The following is a description of a gene set: studied in species Homo sapiens Human Gene Set: GAVISH_3CA_METAPROGRAM_EPITHELIAL_NEUROENDOCRINE from publication Gavish A, Tyler M, Greenwald AC, Hoefflin R, Simkin D, Tschernichovsky R, Galili Darnell N, Somech E, Barbolin C, Antman T, Kovarsky D, Barrett T, Gonzalez Castro LN, Halder D, Chanoch-Myers R, Laffy J, Mints M, Wider A, Tal R, Spitzer A, Hara T, Raitses-Gurevich M, Stossel C, Golan T, Tirosh A, Suvà ML, Puram SV, Tirosh I (PMID 37258682) Genes upregulated in subsets of cells of a given type within various tumors In this study, an extensive analysis was conducted to define meta-programs (MPs) capturing intra-tumor heterogeneity across a spectrum of tumor types. The approach utilized non-negative matrix factorization (NMF) to analyze each cell type separately within individual tumor samples. This involved the analysis of malignant cells, macrophages, fibroblasts, endothelial cells, epithelial cells, T-cells, and B-cells. NMF was executed with varying parameter values (K=4, 5, 6, 7, 8, 9), thereby generating 39 programs for each cell type per sample. Each NMF program was summarized by the top genes based on NMF coefficients.\nRobust MPs were then delineated for each cell type using a set of stringent criteria, including recurrence within the same tumor, similarity to programs in other tumors, and non-redundancy within a tumor. Subsequently, these robust NMF programs were clustered (per cell type) based on Jaccard similarity, leading to the identification of MPs associated with each cell type.\nTo enhance the quality of the MPs, a refinement steps were undertaken, involving the removal of MPs suspected of reflecting low-quality data (with an overrepresentation of ribosomal proteins or mitochondrial-encoded genes), single-study inclusion, or similarity to miss-annotated cell types., and this is the list of marker genes: PCSK1N, FXYD2 (FXYD domain containing ion transport regulator 2), MIR7-3HG, CD99 (CD99 molecule (Xg blood group)), TTR, MAFB, MEIS2, ASB9, SLC30A8, BTG3, SHISAL2B (shisa like 2B), MAP1B, STMN2, BEX1, GCG, PCSK2, SCGB2A1, SEC11C, MEG3, NLRP1, RHOBTB3, CLU, BEX2, CHGA, PAX6, HADH, SCG3, IAPP, SCGN, PFN2, SCG2, PTPRN, NEUROD1 (neuronal differentiation 1), OTULINL, CHGB, GAD2, GNAS, QPCT, TUBA1A, BEX3, ERO1B, RASD1, CPE, SCG5 (NCBI Gene Id 6447), IGFBP7, NKX2-2, UCHL1, INS, PAM, DEPP1